Given this list of marker genes H2AC7, H3C1, PSMA4, SEM1, CDC23, ORC2, MCM4, CDC6, H2BC21, ANAPC15, ORC1, PSMC1 (NCBI Gene Id 5700), UBE2D1, UBE2E1, UBB, H2AB1, PSMC6, ORC3, CDC27, PSMA7, PSMC3, ORC4, H2BC14, H2BC26, H2BC13, ANAPC4, PSMA6, PSMC4, H2BC4, PSMA5 (NCBI Gene Id 5686), PSMB1, ANAPC1, ORC6, ANAPC7, H2BC15, ANAPC11, PSMD14, FZR1, PSMA3, KPNA1, ANAPC10, PSMD12, H2BC17, H2AZ2, MCM3, UBC (ubiquitin C), MCM5, PSMB3, PSMB2, ANAPC2, H2AC18, H2AC4, PSMD3, H2BC9, H2AX, ANAPC5, KPNB1, PSMD13, H2AC20, KPNA6, PSMD6, PSMA1, PSMD11, CDC16, H2BC11, PSMC5, PSMB5, MCM7, PSMA2, UBE2C, H4C1, H2AC14, PSMB4, H2BC1, H2AJ, PSMC2, H3-3A, UBE2S, RPS27A, PSMD1, CDT1, MCM8, H2AC6, PSMB6, MCM2, H2BC5, H3C15, ORC5, H2BC12L, GMNN, PSMD7, ANAPC16, CDC26, PSMB7 (NCBI Gene Id 5695), PSMD2, UBA52, H2BC3, PSMD8, ADRM1, H2BC12, MCM6, here is a description of the gene set: species: Homo sapiens DNA replication pre-initiation in eukaryotic cells begins with the formation of the pre-replicative complex (pre-RC) during the late M phase and continues in the G1 phase of the mitotic cell cycle, a process also called DNA replication origin licensing. The association of initiation proteins (ORC, Cdc6, Cdt1, Mcm2-7) with the origin of replication in both <i>S. cerevisiae</i> and humans has been demonstrated by chromatin immunoprecipitation experiments. In <i>S. cerevisiae</i>, pre-replicative complexes are assembled from late M to G1. In mammalian cells as well, pre-replicative complexes are assembled from late M to G1, as shown by biochemical fractionation and immunostaining. There are significant sequence similarities among some of the proteins in the pre-replicative complex. The ORC subunits Orc1, Orc4 and Orc5 are homologous to one another and to Cdc6. The six subunits of the Mcm2-7 complex are homologous to one another. In addition, Orc1, Orc4, Orc5, Cdc6, and the Mcm2-7 subunits, are members of the AAA+ superfamily of ATPases. Since the initial identification of these pre-RC components other factors that participate in this complex have been found, including Cdt1 in human, <i>Xenopus</i>, <i>S. pombe</i>, and <i>S. cerevisiae</i> cells. Reactome Pathway: Assembly of the pre-replicative complex part of: DNA Replication Pre-Initiation